Given this list of marker genes Adam12, Adam19 (NCBI Gene Id 11492), Adam15, here is a description of the gene set: studied in species Mus musculus part of: Extracellular matrix organization Reactome Pathway: Invadopodia formation electronically inferred by orthology from the curated human pathway This event has been computationally inferred from an event that has been demonstrated in another species.<p>The inference is based on the homology mapping from PANTHER. Briefly, reactions for which all involved PhysicalEntities (in input, output and catalyst) have a mapped orthologue/paralogue (for complexes at least 75% of components must have a mapping) are inferred to the other species.